Given this list of marker genes Pla2g10, Trbv5, Dctn1, Smim11, Lrrc58, Man2a2, Kcnu1, Rtraf, Uck2, Brsk2, Lmod2, Gtf2i, Pdp2, Fam178b, Akirin2 (NCBI Gene Id 67185), Tuba8, Inava, Meox2, Siglece, 4930529K09Rik, Acta1 (actin alpha 1, skeletal muscle), Cenpc1, Cct6b, Lyar, Ift20, Rtn4r, Spag5, ENSMUSG00000122613, Akr1c18, Gnao1, Ighg1, Spc24, Sod3, Phf2, Tcp1, Nuf2, Map2k5, Rspo1, 4930571K23Rik, Pacsin2, Poli, Pabpc4, Fbrsl1, Zfp11, Armc9, Mrpl19, Arhgap4, Patj, Rnf26, Plet1, Nptxr, Slc35b1, Fam3a, Atp6v0d1, Mef2c, Abhd14b, Lhx3, Rnf181, Hmbox1, Ppp1r27, Med17, 3110070M22Rik, Ywhab, Mapk8ip3, Actl6b, Gba1, Cpa5, Tyro3, Gabarapl2, Nbn, Apod, Itpr1, Pvt1, Trem2, Chst11, Chp1, Best1, Asns, Ythdf2, Ambra1, Grip1, Ttll11, Polr1has, Dynlt2b, Cp, Wdr70, Bhlhe22, Mycn, Swap70, Myo1a (NCBI Gene Id 632872), Pus10, Srsf1, Clec3b, Cited2, ENSMUSG00000136050, Pex16, Srf, Cfap144, Dok4, Cdc42ep2, Aff3, Ube4b, Bag6, Gid8, Tssk6, Pygo2, Sox5, Sod1, Ovol2, Car3, Pepd, Rbm12, Apoe, Smu1, Brf1, Pkhd1, 2010203P06Rik, Map1lc3a, Fam186a, Denr, Bcl2a1d, Spp1, Trpc6 (NCBI Gene Id 22068), Strap, Dip2a, Acad9, Zfp830, 1700123O20Rik, Tsc22d4, Fam217a, Tpm3, Gtf2e2, H2-Q5, Spata31d1e, Dguok, Arap1, Cx3cr1, Ebf2, Ccni, Tex48, Col20a1, Ankef1, Tlcd3b, Rpain, Tmem132cos, Krtap5-4 (keratin associated protein 5-4), Coq8a, Spanxn4, Acta2, Raph1, Lyz2, Krtap6-5, Scn1b (sodium channel, voltage-gated, type I, beta), Actg2, 4933406D12Rik, Pdxdc1, Qprt, Eif5a, Calm2, Ttc9, Slc39a13, Tcte1, Gadd45gip1, 1700085D22Rik, Calcoco1, Paqr7, Plac8, Chchd5, Tmem144 (NCBI Gene Id 70652), Nit1, Sar1a, Ltbp4, App, 6330403K07Rik, Arl2, 1110004F10Rik, Smkr-ps, Capn2, Msi1, Lgmn, Ptprjos1, Zfp787, Ogfod2, Cds1, Lgals2, Anp32a, Baiap2, 4930511M18Rik, 1700037C18Rik, Ctsl, Il17a, Tektip1, Gstz1, Rnf19a, Krt2, Ccl27a, Irak1, Tnp2, Otud1, here is a description of the gene set: Chemical induction of squamous tumors in the mouse skin induces multiple benign papillomas: high-frequency terminally benign low-risk papillomas and low-frequency high-risk papillomas, the putative precursor lesions to squamous cell carcinoma (SCC). We have compared the gene expression profile of twenty different early low- and high-risk papillomas with normal skin and SCC. Unsupervised clustering of 514 differentially expressed genes (P<0.001) showed that 9/10 high-risk papillomas clustered with SCC, while 1/10 clustered with low-risk papillomas, and this correlated with keratin markers of tumor progression. Prediction analysis for microarrays (PAM) identified genes that distinguished the two papilloma classes, and a majority of these had a similar expression pattern in both high-risk papillomas and SCC. Additional classifier algorithms generated a gene list that correctly classified unknown benign tumors as low- or high-risk concordant with promotion protocol and keratin profiling. Reduced expression of immune function genes characterized the high-risk papillomas and SCC. Immunohistochemistry confirmed reduced T-cell number in high-risk papillomas, suggesting that reduced adaptive immunity defines papillomas that progress to SCC. These results demonstrate that murine premalignant lesions can be segregated into subgroups by gene expression patterns that correlate with risk for malignant conversion, and suggest a paradigm for generating diagnostic biomarkers for human premalignant lesions with unknown individual risk for malignant conversion. Mouse Gene Set: DARWICHE_PAPILLOMA_RISK_HIGH_DN Genes down-regulated during skin tumor progression from normal skin to high risk papilloma. from publication Darwiche N, Ryscavage A, Perez-Lorenzo R, Wright L, Bae DS, Hennings H, Yuspa SH, Glick AB (PMID 17525749) species: Mus musculus